Given this list of marker genes SPATA18, TAMM41, PLA2G4A, PLA2G3, LCLAT1, THEM5, PLA2G4B, PGS1, CDS2, LPGAT1, PTPMT1, CRLS1, PLA2G4F, LPCAT1, PHB2, PLA2G1B, PLA2G10, PLA2G2E, PLB1, TAFAZZIN, PLA2G6, PLA2G2D, SERAC1, HADHA, MECP2, PNPLA8 (NCBI Gene Id 50640), PLA2G4D, PLA2G2A, DNAJC19, OC90, PLA2G2F, PLA2G2C (phospholipase A2 group IIC), GPAM, PLA2G15, LPCAT4, ABCA3, PLA2G5, here is a description of the gene set: The chemical reactions and pathways involving phosphatidylglycerols, any of a class of phospholipids in which the phosphatidyl group is esterified to the hydroxyl group of glycerol. They are important constituents of cell membranes. Human Gene Set: GOBP_PHOSPHATIDYLGLYCEROL_METABOLIC_PROCESS species: Homo sapiens